The following is a description of a gene set: Human Gene Set: GOBP_MATURATION_OF_LSU_RRNA species: Homo sapiens Any process involved in the maturation of a precursor Large SubUnit (LSU) ribosomal RNA (rRNA) molecule into a mature LSU-rRNA molecule., and this is the list of marker genes: RBM34, EIF6, RPL35, PPAN, NSA2, LAS1L, RPF1, NOL9, MAK16, RPL7A, PES1, PAK1IP1, NOP2, RPL7L1, WDR12, ZNHIT6 (zinc finger HIT-type containing 6), FTSJ3, URB1, BOP1 (BOP1 ribosomal biogenesis factor), DDX18, TRMT112, RPF2, RRP15, ZNHIT3, GTPBP4, RPL7